The following is a description of a gene set: Mouse Gene Set: MIR_292B_5P species: Mus musculus Genes predicted to be targets of miRBase v22 microRNA mmu_miR_292b_5p in miRDB v6.0 with MirTarget v4 prediction scores > 80 (high confidence targets). from publication Chen Y, Wang X (PMID 31504780), and this is the list of marker genes: Nab1, Cdk7, Ppp3ca, 1700066M21Rik, Tenm4, Ssx2ip, Map2k6, Sike1, Sprr2a2, Cnot6l, Psmd9, Edem1, Oprk1, Acot2, Fsd1l (NCBI Gene Id 633268), Tafazzin, Lin52, Entpd7 (ectonucleoside triphosphate diphosphohydrolase 7), Rab11fip1, Nabp1, Orc2, Abraxas2, Dnal1, Steap2, Dclk1, Eda2r, Resf1, Speer4f1, Gja1, Tmem263, Mapk13, Rtkn2, Elovl5, Isl1, Ptges3, Nip7, Ubxn2a, Vhl, Tasor, Fbxl14, Zfp770, Ap1g1, Dync2i1, Vldlr, Clic5, Wdr31, Ubr1, Svbp, Med27, Dcun1d1, Eif4e, Cstf2t, Glt8d1, Ppm1e, Atad5, Vps26a, Ncam1, Hsf3, Dazap1, Itpripl1, Col8a1, Zfp574, Idi1, Actmap, Nol4, Adamdec1, Efnb1, Fut10, C5ar2, Mapk8, Foxp2, Hapln2, Ildr2, Ube2v2, Ubap1, Akr1d1, Ammecr1l, Relch, Pik3ca, Tef, Klf9, Krtap3-1, Tmem175, Gpr176, Uevld, Surf4, Mrpl45, Foxr1, Zfp560, Shh, Svs6, Yipf5, Rbfox2, Kdm7a, Ppfia3, Btg1, Polr3gl, Or2ag2b, Appl1, Soat1, Peli2, Klf6 (Kruppel-like transcription factor 6), Eral1, Fkbp3, Cep126, Tab3, Ssbp2, Snai2, Jak2, Mapre1, Gpr157, Kpna3, Slc35b3, Pdik1l, Tbl1xr1, Bdnf, Igf2bp3, Syt4, Arhgap35, Ric3, Mrps24, Samd8, Naa40, Rorb, Edaradd, Neurod4, Arap2, Plagl1, Cfl2, Bag3, Decr2, Tenm2, Car5b, Dmac1, Gal3st3, Ucp1, Hdac8, Or7e176, Nap1l1, Hnrnpf, Samd3, Gk, Kmt5b, Sirt6, Cebpb, Spam1, Nipal4, Pxmp4, Cep97, Hsdl1, 6430571L13Rik (NCBI Gene Id 235599), Mapk1ip1l, Bpnt2, Togaram1, Kdelr2, Hspb3, Ccdc127, Ryr2, Coa3, Prkacb, Slc35e1, Sdf2l1, Efcab14, Epb41l5, Dmrta1, Lrrn4cl, Tmem87a, Slc35a5, Slain1, Wdr82, Phf14, Prune1, Kdm1a, Patj, Klf8, Ctsa, Rc3h2, Ccar1, Topbp1, Wdfy1, Usp33, Tfb2m (NCBI Gene Id 269153), Lats1, Ube2k, Car8, 0610040J01Rik, Noc3l, Hmbox1, Syn3, Rigi, Olr1, F2rl2, Ipmk, Dscaml1, Krt2, Gabpa (NCBI Gene Id 14390), Kalrn, Zc3h6, Wtap, Tnfrsf9, Per3, Dzip1l, Jcad, Nbeal1, Adra2b, Phactr4, Cacna1d, Gtpbp10 (NCBI Gene Id 74800), Commd8, Insr, Hat1, Arfip1, Pgr, Adgrf2, Krr1, Reps2 (NCBI Gene Id 237196), Fbxo27, Il27ra, Cdkn2aip, Fgf14, Spink5 (NCBI Gene Id 72432), Ppp4r3b, Rps6kb1, Fnbp4, Wnk3, Zfp719, Ttyh2, Abhd5, Tmem167b, Ifi213, Nav1, Elavl2, Tpbg, Asap2, Sh3glb1, Mobp, Phf20l1, Heatr3, Mllt10, Aftph, Leng8, Pip5k1c, Abcb10, Dnajc19, Zfp446, Znrf3, Diaph2, Zfp345, Zbtb41, Cd300a, Usp7, Mmachc, Kif3a, Gemin5, Atp6v1g1, Dr1, Eif4e3, Msl3, Cracd, Csde1, Ltn1, Pank3, Plekhh1, Ube3a, Tulp2, Atxn7, Cbx5, Dnajc18, Rufy2, Ttll1, Prpf40a, Mylk4, Pvr, Ammecr1, Phtf2, Mfsd4a, P2ry10b, Lrat, Cldn6, Wdr44, Pter, Arpc3, Creb1 (cAMP responsive element binding protein 1), Ostn, Mga, Cdk12, Sass6, Ythdf3, Zfp788, Cd226, Lonrf2, Rfxank, Ghitm (growth hormone inducible transmembrane protein), Sprr2a1, Uhrf1, Bmal2, Slc5a3, Pgm3, Ppp1r15b, Topors, Tut7 (NCBI Gene Id 214564), Vcpkmt, Spib, Cited2, Snip1, Rfx8, Krit1, Nop9, Slc16a9, Eef1d, Mlph, Xpo1, Tra2b, Tenm3, Rps15a, Atl3, Ppih, Kctd9, Uvssa, Csk, Hapln1, Ap2a2, Cd164, Edem2, Pcdhb4, Ppp4c, Cnpy1, Tnrc6b, Zfp865, Sp9, Zfp1006, Ncl, Lrp2, Sgcb, Agpat1, Plcl1, Tbc1d32, Rdh16, Cyld, Zfp422, Tgfbr1, Rab1a, Blnk, Ldhc, Sgo1, Cyp1a2, Zcchc14, Fgf12, Zfp281, Iws1, Fbp1, Mdm4, Zbtb24, Vps13c, Rlim, Tmem170b, L3mbtl2, Dbr1, Fam199x, Kbtbd11, Hhat, Csgalnact2, Cadm2, Wdr37, Krt222, Atp6v0a2, C5ar1, Ebf2, Tmem33, Larp4, Eef1a1